The following is a description of a gene set: Increased circulating globulin level Human Gene Set: HP_INCREASED_CIRCULATING_GLOBULIN_LEVEL An abnormally elevated concentration of globulins in the blood. studied in species Homo sapiens, and this is the list of marker genes: PTPN22, P4HA2 (prolyl 4-hydroxylase subunit alpha 2), ALB, HLA-DRB1, HLA-B